The following is a description of a gene set: Regulatory CD4+ T cells (Tr cells), the development of which is critically dependent on X-linked transcription factor Foxp3 (forkhead box P3), prevent self-destructive immune responses. Despite its important role, molecular and functional features conferred by Foxp3 to Tr precursor cells remain unknown. It has been suggested that Foxp3 expression is required for both survival of Tr precursors as well as their inability to produce interleukin (IL)-2 and independently proliferate after T-cell-receptor engagement, raising the possibility that such 'anergy' and Tr suppressive capacity are intimately linked. Here we show, by dissociating Foxp3-dependent features from those induced by the signals preceding and promoting its expression in mice, that the latter signals include several functional and transcriptional hallmarks of Tr cells. Although its function is required for Tr cell suppressor activity, Foxp3 to a large extent amplifies and fixes pre-established molecular features of Tr cells, including anergy and dependence on paracrine IL-2. Furthermore, Foxp3 solidifies Tr cell lineage stability through modification of cell surface and signalling molecules, resulting in adaptation to the signals required to induce and maintain Tr cells. This adaptation includes Foxp3-dependent repression of cyclic nucleotide phosphodiesterase 3B, affecting genes responsible for Tr cell homeostasis. from publication Gavin MA, Rasmussen JP, Fontenot JD, Vasta V, Manganiello VC, Beavo JA, Rudensky AY (PMID 17220874) studied in species Mus musculus Genes changed in peripheral regulatory T lymphocytes that depend on PDE3B. Human Gene Set: GAVIN_PDE3B_TARGETS, and this is the list of marker genes: SYTL1, NCF1, SYT11, TGFB1, TFPI, GZMB, LAMC1, NT5E, HMOX2, FGL2, IL2RA, SYTL2, TNFSF10, F13A1, CYBB, IL10, ENTPD1, EBI3, NCF4, CTLA4, IL18, SYPL1